Given this list of marker genes LRRC49, FAM72A (NCBI Gene Id 729533), ARHGEF17, ZCCHC3, SAP30, SMIM30, KCTD5, BMX, PPP1R15B, AKAP1, PDGFRA, RIPK3, FGB (NCBI Gene Id 2244), POLR3B, KIAA1549, SPOUT1, BPIFC, TGM1, SLC14A1, COL11A2, SRBD1 (S1 RNA binding domain 1), PSPC1, CCDC88C, IDH3A, MYH1, FOXRED2, PNMA1, COG6, B4GALNT4, CABCOCO1, YDJC, SECISBP2, SNX21, PLSCR1, VPS50, WDR4, TBL2, CA12, HS6ST1, DLG1, USP31, RGL1, ABHD17C, METTL16, ADORA2B (adenosine A2b receptor), C11orf24, TIMM8A, EVI2B, JDP2, PEDS1, MDC1, AQP9, C8A, FAM149B1, CNTROB, NCK2, GPR132, TMEM154, KCNG1, RABGGTA, DMWD, BRAF, PFKP, IL7 (NCBI Gene Id 3574), MINPP1, NCBP1 (nuclear cap binding protein subunit 1), SLC2A3, LRRC24, VPS26C, GLB1L3, PHF6, MPG, SLC35D1 (NCBI Gene Id 23169), MDM2, KIAA0319L, FAM117A, KLF2 (KLF transcription factor 2), BYSL, NUP42, SPIC, IL11, TNFSF9, POU6F1, NOC3L, ARHGEF18, FLNB, APOA4, RAB4A, DNAAF2, ALDH18A1, CHRM3, EARS2, SUPV3L1, IL15RA, SMCO4, AATF, ACADVL, CDV3, CDPF1, DUSP12, APLN, ZSWIM3, FAM43A, NUP155, THBS1, CD47, HSD3B7, SELL, NOP56, FUT4, PANX1, ABCC1, SPOP, CFAP96, RRAGC, METTL18, ROCK2, CYP4X1, TMA16, AFM, PUS3, KCNK5, RRP1B, ATG4D, PRDM8, TTLL10, HCN1, CALHM6, XPNPEP3, HK2 (NCBI Gene Id 3099), GTF2E2, CRIPTO, KIT, MDM4, RMND1, TBC1D4 (TBC1 domain family member 4), CCND1, PIM3, MAGOHB, AJUBA, TNFRSF18, COX10, IKZF1, CHCHD4, ETS2, ATP11A, GIMAP1, NDST1 (N-deacetylase and N-sulfotransferase 1), IL31RA, ATP8A1, METTL6, TSACC, POU5F1, ERCC8, CFAP107, ANKRD37, DENND1C, SLC5A6, PYCR2, DHODH, ZDHHC17, SENP5, TRIM44, BANP, RARS1, ITPRIPL1, GUCA1B, TIAM1, INPP5B, EAF1, C2orf49 (NCBI Gene Id 79074), TNFRSF21, RNF41, CLEC10A, WDR54, LDLRAD3, RADIL, VILL, RAB11FIP1, KRT4, PML, SLC22A25, URB2, TMEM120A, RCBTB1, E2F6, SLC9A9, RPP14, CCDC137, PPP2R5A, SERPINA6, VTI1A, PAFAH1B2, FGD2, MEF2D, P2RX4, ST3GAL1, ADCK1, STX7, here is a description of the gene set: Human Gene Set: GSE25088_ROSIGLITAZONE_VS_IL4_AND_ROSIGLITAZONE_STIM_MACROPHAGE_DAY10_DN studied in species Homo sapiens C57Bl/6 wild-type and STAT6 KO mice were used to study PPARg and IL-4 signaling. Bone marrow of 3 mice per group was isolated and differentiated to macrophages with M-CSF (20 ng/ml). 20 ng/ml IL-4 was used to induce alternative macrophage activation and 1 uM Rosiglitazone (RSG) was used to activate PPARg. From each mouse 4 samples were generated: 1. M-CSF, 2. M-CSF+RSG, 3. IL-4 and 4. IL-4+RSG. All compounds were added throughout the whole differentiation process, and frech media was added every other day. Control cells were treated with vehicle (DMSO:ethanol). After 10 days, RNA was isolated and gene expression profiles were analyzed using Mouse Genome 430 2.0 microarrays from Affymetrix. Genes down-regulated in wildtype bone marrow-derived macrophages treated with rosiglitazone: control versus IL4. from publication Szanto A, Balint BL, Nagy ZS, Barta E, Dezso B, Pap A, Szeles L, Poliska S, Oros M, Evans RM, Barak Y, Schwabe J, Nagy L (PMID 21093321)